Given this list of marker genes B3gnt4, B4galt3, B4galt4, B3gnt2, Chst5 (NCBI Gene Id 56773), Kera, St3gal4, B4galt2, Chst1, Fmod, Chst2, Lum, B4gat1, B4galt1, St3gal1, B4galt6, Slc35d2, B4galt5, B3gnt7, B3gnt3, Omd, St3gal6, St3gal2, St3gal3, Acan, Prelp, Ogn (osteoglycin), here is a description of the gene set: Keratan sulfate biosynthesis studied in species Mus musculus Mouse Gene Set: REACTOME_KERATAN_SULFATE_BIOSYNTHESIS